Given this list of marker genes Dipk1a, Usp2, Nedd1, Psma5, Pcdhb18, Mtmr9, Zmat3, Rem2, Emp1, Ybx3 (NCBI Gene Id 56449), Fgf9 (NCBI Gene Id 252883), Map3k13, Arid4a, Cacnb4, Mpv17l, Usp42, Camta1, Slc16a14, Ube3a, Neurod4, Zfp936, Mtrf1l, Gemin6, Golt1a, Gcn1, Nkd1, Ftmt, Antxr2, Rtn3, Slc25a16, Cimip3, Ltbp4, Epc1, Git1, Nxt2, Ubap2l, Aldoart1, Cxxc1, Stx12, Nell2, Usp7, Mbtd1, Fam222b, Tmem123, Arhgdib, Ptprc, Acnat1, Tbx15, Adam28, Ttc23, Srsf4, Lsm12 (NCBI Gene Id 68741), Sft2d2, Rb1cc1, Gad1, Ncbp3, Aadat, Aebp2, Rab2a, Pkig, Slc25a25, Kif18a, Lrrc4c, Kcnk10, Hecw2, Phip, Gla, Nr4a2, Nudt16l1, Lima1, Crppa, Ammecr1, Hdgfl3, Wdr26, Zfp775, Tfrc (NCBI Gene Id 76361), Smg1, Rpl39, Arhgef11, Map7d2 (NCBI Gene Id 78283), Rsf1, Minar1, Ppp3ca, Hdac9, Dgcr8, Fndc3b, Kifc2, Phospho1, Ppm1e (protein phosphatase 1E (PP2C domain containing)), Cast, Arhgef6, Birc6, Neu3, Ppp4r3a, here is a description of the gene set: Mouse Gene Set: MIR_7652_5P species: Mus musculus from publication Chen Y, Wang X (PMID 31504780) Genes predicted to be targets of miRBase v22 microRNA mmu_miR_7652_5p in miRDB v6.0 with MirTarget v4 prediction scores > 80 (high confidence targets).